The following is a description of a gene set: species: Homo sapiens Genes up-regulated in CD4 T cells treated with pioglitazone and over-expressing: FOXP3 and PPARg2 isoform of PPARG versus FOXP3. We identified Pparg as a major orchestrator of the phenotype of adipose-tissue resident regulatory T cells (VAT Tregs). To explore the contribution of Pparg1 and 2 in the generation of the VAT Tregs-specific gene signatures, CD4+FoxP3- T cells were transduced with Foxp3+/- Pparg1 (or Pparg2), treated with Pioglitazone or vehicle, and double sorted for microarray analysis. Human Gene Set: GSE37533_PPARG2_FOXP3_VS_FOXP3_TRANSDUCED_CD4_TCELL_PIOGLITAZONE_TREATED_UP from publication Cipolletta D, Feuerer M, Li A, Kamei N, Lee J, Shoelson SE, Benoist C, Mathis D (PMID 22722857), and this is the list of marker genes: LAD1, HCG9, TNFSF14, CALHM2 (calcium homeostasis modulator family member 2), MN1, HOXA11, ZNF280D, NEFM, PLK2, REST, ALX4, MBNL1, TIAM2, RIMS3, PLSCR4, GIT2, RAMP1, LRRC14, ZNF195, PDGFRA, UBL3, CPN1, PLSCR3, MTMR6, POTEKP, USP8, GPR50, DEFA5, ZHX3, ATP7B, UBE2D1, ZNF587, OAT, CAB39L, VNN3P, IGSF9B, HOXC5, ACSS3, LRRC8D, SEC14L5, PHC3, SYT5, MTERF3, DGCR11, FRAT2, ME1, UBTF, ZNF225, AKR1B10, DPT, TRAPPC14, ARL4D, SLC22A18AS, TCEAL1, H2AC4, HTATIP2, KRT75, PVT1, POLR2H, VIP, RPL23AP32, PLAGL2, ITGAL, MOG, CCDC25, WDR91, PSG6, MARCHF7, PIK3R5, PTBP2, TCF7, GLRB, LSR, IER3, RIT1, CLDN14, RAB1A, RAB35, HERPUD1, AIRIM, MYH7, DOC2B (NCBI Gene Id 8447), NDUFAF7 (NCBI Gene Id 55471), COX6C (cytochrome c oxidase subunit 6C), OBSCN, SEPHS2, ADAM9, ZNF211, TRAK2, CCT6B, CSTF1, HGFAC, PRDM9, EIF4A2, IL6ST, LCN2, USH1C, RGS9, PATJ, LSM5, ACSM5, DOCK9, EOLA1, RIPK4, ACAP2, CYBRD1, CEBPA, ZNF160, SEMA4C, S100A1, CES1, RTN2, SLC35E1, SPRY2, ZNF551, TMUB2, RCVRN, SOX17, WEE1 (WEE1 G2 checkpoint kinase), TRIM46, CCN2, SP3, FZD3, CYP3A4, SLC19A4P, FBXL5, DSTNP2, EVI5, SLC18A3, NUBPL, BAG4, KLF15, BMP6, POLH, MINDY1, MFAP1, GNPTAB, CLP1, PRR36, PPARA, DCLK2, STON1, ITGB7, MAP3K10, ELF3, IL23A, MT3, JRKL, DIRAS3, SCN5A, XRCC4, DGKQ, VPS13A, PTTG1, COL5A2, ALX3, ENSG00000274253, COMMD8 (NCBI Gene Id 54951), GPR173, SGCG, PNMA1, FBXW4P1, PRODH, PDE3A, PDZRN3, GTF3C4, FADS2, WRNIP1, CTNND2, HMGN2, TPT1P8 (NCBI Gene Id 59347), VAMP1, DNMT3A, TMEFF1 (transmembrane protein with EGF like and two follistatin like domains 1), RSBN1, THEM6, NR5A2, TMPRSS5, CALML3, LIG3, MUC3A, NHERF1, NUDT9, RARS1, KLHL4, CALU, INO80D, ISOC1, SH3BP4, RASGRF1, CCDC51, MARK2, DDHD2, CFAP69, TMEM165, DUOX1 (dual oxidase 1), ZNF112, B3GAT1, CITED2, ARRB2